The following is a description of a gene set: Genes up-regulated in day 6 embryoid bodies derived from embryonic stem cells (ES) with HEX knockout. studied in species Mus musculus The first hematopoietic and endothelial progenitors are derived from a common embryonic precursor termed the hemangioblast. The genetic cascades that regulate the differentiation of the hemangioblast to hematopoietic and endothelial cells are largely unknown. In general, much of embryonic development is coordinately regulated by temporal and spatial expression of transcription factors, such as the Homeobox (Hox) gene family. We and others isolated a divergent homeobox gene termed Hex (or Prh) that is preferentially expressed in hematopoietic and endothelial cells. Using in vitro Hex-/- embryonic stem (ES) cell differentiation, in vivo yolk sac hematopoietic progenitor assays, and chimeric mouse analysis, we found that Hex is required for differentiation of the hemangioblast to definitive embryonic hematopoietic progenitors and to a lesser extent endothelial cells. Therefore, Hex is a novel regulator of hemangioblast differentiation to hematopoietic and endothelial cells. from publication Guo Y, Chan R, Ramsey H, Li W, Xie X, Shelley WC, Martinez-Barbera JP, Bort B, Zaret K, Yoder M, Hromas R (PMID 12791650) Human Gene Set: GUO_HEX_TARGETS_UP, and this is the list of marker genes: IQGAP1, EPHA4, VEGFA, AKAP12, RTN1, AGFG1, MAGEL2, UBE3A (NCBI Gene Id 7337), FZD4, ENPP5, SPG21, CALM3, NNAT, WWC2, ABCD4, SFRP2, PGF, CIC, EFNA2, SATB1, TBX3, MTF2, CMTM6, RRAGD, PTPN1, GNG3, DIAPH2, GRIK5, POU2F1 (NCBI Gene Id 7823), DHX36, LIFR, BPNT2, SLC6A6, SOX11, FGD1, WWTR1, CD2BP2, BMP4, SMARCC1, STIL, FBLN2, EFNA3, EXT1, NAA15, MARK2, KDM6A, KLF7, LUC7L2, PTPN13, SRSF7, PTEN, ATXN2, PCM1, CD99, GLG1, ENY2, NRP1, REST, IGF1R, AKTIP, SP1, PURA, TBL1X, WDR26, URM1 (ubiquitin related modifier 1), NDN, AKAP8, ERF, ZNF322, ARSA, HOXD1, ATP6V1A, ELOVL6, TES, ISLR, PCGF2, CD59, ZFHX3